The following is a description of a gene set: Division of a stem cell during which it retains its identity and buds off a daughter cell with a new identity. species: Mus musculus Mouse Gene Set: GOBP_ASYMMETRIC_STEM_CELL_DIVISION, and this is the list of marker genes: Zbtb16, Etv5, Stra8, Cntrl, Ing2